Given this list of marker genes PIK3R1, GRB2 (growth factor receptor bound protein 2), SH2B2, SHC1, GAB2, IRS2, DOK2, SH2B3, FRS2, FRS3, TRAT1, IRS1, BLNK, GAB4 (GRB2 associated binding protein family member 4), TRADD (TNFRSF1A associated via death domain), SH2B1, STAP1, here is a description of the gene set: Human Gene Set: GOMF_TRANSMEMBRANE_RECEPTOR_PROTEIN_TYROSINE_KINASE_ADAPTOR_ACTIVITY The binding activity of a molecule that brings together a transmembrane receptor protein tyrosine kinase and one or more other molecules, permitting them to function in a coordinated way. species: Homo sapiens